Given this list of marker genes MAPK3, NRAS, BRAF, SOS1, ARAF, GRB2, MAP2K2 (NCBI Gene Id 85511), KRAS, MAPK1, RAF1, MET, SOS2, HRAS, MAP2K1, here is a description of the gene set: MET-overexpression to RAS-ERK signaling pathway. Pathway ID: N00248. Pathway type: Variant. Pathway class: nt06263 Hepatocellular carcinoma. Human Gene Set: KEGG_MEDICUS_VARIANT_MET_OVEREXPRESSION_TO_RAS_ERK_SIGNALING_PATHWAY Pathway Definition from KEGG: MET* -> GRB2 -> SOS -> RAS -> RAF -> MEK -> ERK species: Homo sapiens